The following is a description of a gene set: Mouse Gene Set: GOMF_SOLUTE_SODIUM_SYMPORTER_ACTIVITY species: Mus musculus Enables the transfer of a solute or solutes from one side of a membrane to the other according to the reaction: solute(out) + Na+(out) = solute(in) + Na+(in)., and this is the list of marker genes: Slc13a3, Slc23a1, Slc10a1, Slc38a4, Slc4a5, Slc6a2, Slc6a12 (solute carrier family 6 (neurotransmitter transporter, betaine/GABA), member 12), Slc5a4b, Slc17a8, Slc20a1, Slc5a12, Slc6a4, Slc6a9, Slc6a6, Slc13a1, Slc28a3, Slc6a15, Slc5a7, Slc18a2, Slc1a3, Slc13a2, Slc5a3, Slc29a1, Slc6a8, Slc4a10, Slc17a6, Slc38a1, Slc10a4-ps (solute carrier family 10 (sodium/bile acid cotransporter family), pseudogene), Slc6a3, Slc6a14, Slc5a2 (solute carrier family 5 (sodium/glucose cotransporter), member 2), Gm5134, Slc10a5, Slc10a6 (solute carrier family 10 (sodium/bile acid cotransporter family), member 6), Slc23a2, Slc34a1, Slc13a4, Slc6a7, Slc18a1, Slc1a1, Slc22a1, Mfsd2a (MFSD2 lysolipid transporter A, lysophospholipid), Slc28a1, Slc12a3, Slc5a10, Slc13a5, Slc4a4, Slc28a2, Slc6a1, Slc4a9, Slc10a2, Slc5a6, Slc5a9, Slc5a4a, Slc17a7, Slc1a6, Slc5a8, Slc1a7, Slc22a3, Slc5a5, Slc38a3, Slc5a11, Slc12a1, Slc10a3, Slc6a11, Slc6a20b, Slc20a2, Slc6a18, Slc34a2, Slc5a1, Slc12a2, Slc38a2, Slc34a3, Slc4a8, Slc6a20a, Slc1a2, Slc38a7, Slc28a2b, Slc4a7, Slc10a4, Slc6a5, Slc6a13